Given this list of marker genes Kcnh5, Kcng1, Kcnn3 (potassium intermediate/small conductance calcium-activated channel, subfamily N, member 3), Kcna4, Kcnh8, Kcnh1, Kcnb1, Kcng4, Gnb3, Hcn1, Kcna2, Kcnd2, Gabbr2, Kcnj14, Kcnh2 (NCBI Gene Id 16511), Kcnj2, Kcnmb4, Kcns1, Kcna3, Kcnk7, Kcnf1, Kcnq4, Kcnc3, Gng5, Kcnab3, Kcna6, Kcnj16, Hcn3, Kcns3, Gngt2, Kcnk13, Kcnd1, Kcnk1, Gng11 (guanine nucleotide binding protein (G protein), gamma 11), Kcnk4, Kcnj4, Kcnmb3, Kcnv2, Gng7, Kcnj9, Gng10, Gngt1, Kcnj10, Kcnj11, Gng4, Gng2, Kcnn4, Hcn2, Kcnq1, Kcnab2, Kcnn1, Kcnq5, Kcnk2 (NCBI Gene Id 98453), Gabbr1, Kcnh4, Kcnj5, Kcnj3, Gnb1, Gnb5, Kcna1, Abcc9, Kcna7, Gng12, Kcnab1 (NCBI Gene Id 16497), Kcnj1, Kcnj8, Kcnj15, Kcnd3, Kcnk10, Kcnc4, Gng8, Kcns2, Kcnk6, Kcnk16, Kcnmb2, Kcnk18, Kcnh6, Gng3, Kcna5, Kcng3, Kcnj6, Kcnv1, Kcnb2 (NCBI Gene Id 98741), Kcnc2, Gng13, Gnb4, Kcnk9, Kcnh7, Kcnk3, Hcn4, Kcnj12, Kcng2, Gnb2, Abcc8, Kcnc1, Kcnh3, Kcna10, here is a description of the gene set: species: Mus musculus Potassium Channels Mouse Gene Set: REACTOME_POTASSIUM_CHANNELS